Given this list of marker genes Tns3, Mrps11, Ripor1, Traf3ip3, Marchf5, here is a description of the gene set: Cytokines mediate cell-cell communication in the immune system and represent important therapeutic targets. A myriad of studies have highlighted their central role in immune function, yet we lack a global view of the cellular responses of each immune cell type to each cytokine. To address this gap, the authors created the Immune Dictionary, a compendium of single-cell transcriptomic profiles of more than 17 immune cell types in response to each of 86 cytokines (>1,400 cytokine-cell type combinations) in mouse lymph nodes in vivo. A cytokine-centric view of the dictionary revealed that most cytokines induce highly cell-type-specific responses. For example, the inflammatory cytokine interleukin-1β induces distinct gene programmes in almost every cell type. A cell-type-centric view of the dictionary identified more than 66 cytokine-driven cellular polarization states across immune cell types, including previously uncharacterized states such as an interleukin-18-induced polyfunctional natural killer cell state. Genes positively differentially expressed in cell type: ILC (innate lymphoid cell) upon treatment with cytokine: SCF in mouse lymph nodes in vivo. studied in species Mus musculus from publication Cui A, Huang T, Li S, Ma A, Pérez JL, Sander C, Keskin DB, Wu CJ, Fraenkel E, Hacohen N (PMID 38057668) Mouse Gene Set: CUI_ILC_SCF_RESPONSE_UP